Given this list of marker genes TPSAB1 (NCBI Gene Id 82314), ADAMTS18, FN1, JAM2, MMP17, CEACAM6, CTSG, KLK7, CD44, CRTAP, LAMA1, CAPN14, FGB, TLL1, FGG, COL20A1, VCAN, ADAMTS4, ACTA1, ACTB, LAMA3, COL4A1, ITGAX, BCAN, JAM3, COL11A2, VCAM1, HTRA1, MMP25, COMP, COL7A1, COL25A1, COL6A1, ADAMTS16, TIMP1, COL8A1, MMP11, PTPRS, PLOD2, CAPN8, COL22A1, SCUBE1, ASPN, KLK2, PLEC, DCN, FBN3, CD151, APP, SGCZ, SNTG2, ICAM2, PSEN1, FGF2, CAST, TGFB1, P3H2, LTBP4 (latent transforming growth factor beta binding protein 4), FURIN, ADAM15, CAPN15, NID2, MFAP2, SERPINH1, COL6A5, COL28A1, P3H1, EMILIN1, SPARC, COL12A1, FBLN1, ACTG1 (actin gamma 1), MATN3, DAG1, COLGALT2, SGCB, ADAM9, OPTC, ICAM5, ITGAV, COL3A1, COL21A1, NCSTN, MMP24, COL4A2, TNR, EFEMP1, CD47, SPOCK3, COL5A1, COL14A1, ADAM8, ITGA8, CTSL, SH3PXD2A, P3H3, CAPN7, ADAMTS14 (ADAM metallopeptidase with thrombospondin type 1 motif 14), CAPN11, SDC2, ELANE, FMOD (NCBI Gene Id 2331), PLG, MATN4, CAPN10, NRXN1, ITGB1, ITGB2, COL10A1, BMP2, CAPN2, DMP1, LTBP3, P4HB, EMILIN3, ADAM12, DRP2, TTR, SNTB1, COL27A1, LOXL1, COL13A1, FBN2, COL9A2, KDR, CAPN3, EFEMP2, ITGAM, CTSB, LAMA5, TNC, COL18A1, DTNA, COL1A1, ITGB5, CAPN13, PRKCA, ADAMTS2, LAMC3, TRAPPC4, COL4A5, MFAP3, SDC1, ACTN1, SCUBE3, TGFB2, GDF5, CAPN9, ADAM19, LOXL4, BMP10 (NCBI Gene Id 27302), LOXL2 (lysyl oxidase like 2), MMP16, PXDN, CTSD, MADCAM1, COL11A1, ICAM3, ITGA2B, SERPINE1, MMP15, KLKB1, MMP7, LAMC1, ADAMTS8, MMP12, FBN1, SPP1, CTSV, CTRB2, PECAM1, ITGB8, ITGB6, MMP3, COL5A3 (NCBI Gene Id 50509), MMP9 (matrix metallopeptidase 9), SNTB2, SGCA, A2M, DSPP (dentin sialophosphoprotein), ADAMTS9, COL8A2, ITGAD, MATN1, CAPNS2 (calpain small subunit 2), COL1A2, LAMC2, SGCG, COL2A1, CAPN12, LUM, PRSS1, ITGB3, COL17A1, LAMA4, HSPG2, FGA, NCAN, DMD, DDR2 (NCBI Gene Id 4921), ELN, ADAM17, MMP2, ITGA6, PLOD3, BSG, COL4A4, ITGA11, AGRN, MUSK, ADAM10, FBLN5, ITGA4, CTSS, CASP3, ITGA3, ADAMTS1, HAPLN1, COL24A1, ADAMTS3, EMILIN2, ACAN, PPIB, PDGFA, F11R, ACTA2 (NCBI Gene Id 59), MMP13, COL6A2, LAMB3, PCOLCE, ITGA2, MFAP5, SSPN, TIMP2, ITGAL, DST, COL19A1, NTN4, COL6A3, LAMB1, DTNB, NCAM1 (neural cell adhesion molecule 1), CEACAM8, LTBP1, LOXL3, P4HA1, LOX, TLL2, CAPN6, LRP4, PCOLCE2, CAPNS1, PLOD1, ACTG2, BMP4, MFAP4, CAPN5 (calpain 5), COL26A1, ITGB4, CMA1, LAMA2, BMP7, ICAM4, MMP14, P4HA2, SNTA1, COL16A1, BGN, ITGAE, SGCD, SDC3, COL4A3, CEACAM1, TNXB, UTRN, COL6A6, PRSS2, CDH1, COLGALT1, ITGA7 (integrin subunit alpha 7), PHYKPL, CAPN1, CASK, MMP20, MMP19, COL15A1, TGFB3, NID1, COL4A6 (collagen type IV alpha 6 chain), MMP10, MMP1, CTSK (NCBI Gene Id 1513), COL5A2, P4HA3, ICAM1, ADAMTS5, VTN, COL23A1, ITGA9, TNN, TMPRSS6, ITGB7, LTBP2, MMP8, VWF, PDGFB, FBLN2, THBS1, COL9A1, IBSP, ITGA10, ACTC1, CTRB1, SGCE, DDR1, COL9A3, SDC4, ITGA5, ITGA1, LAMB2, BMP1, here is a description of the gene set: species: Homo sapiens The extracellular matrix is a component of all mammalian tissues, a network consisting largely of the fibrous proteins collagen, elastin and associated-microfibrils, fibronectin and laminins embedded in a viscoelastic gel of anionic proteoglycan polymers. It performs many functions in addition to its structural role; as a major component of the cellular microenvironment it influences cell behaviours such as proliferation, adhesion and migration, and regulates cell differentiation and death. <br><br>ECM composition is highly heterogeneous and dynamic, being constantly remodeled and modulated, largely by matrix metalloproteinases (MMPs) and growth factors that bind to the ECM influencing the synthesis, crosslinking and degradation of ECM components. ECM remodeling is involved in the regulation of cell differentiation processes such as the establishment and maintenance of stem cell niches, branching morphogenesis, angiogenesis, bone remodeling, and wound repair. Redundant mechanisms modulate the expression and function of ECM modifying enzymes. Abnormal ECM dynamics can lead to deregulated cell proliferation and invasion, failure of cell death, and loss of cell differentiation, resulting in congenital defects and pathological processes including tissue fibrosis and cancer.<br><br>Collagen is the most abundant fibrous protein within the ECM constituting up to 30% of total protein in multicellular animals. Collagen provides tensile strength. It associates with elastic fibres, composed of elastin and fibrillin microfibrils, which give tissues the ability to recover after stretching. Other ECM proteins such as fibronectin, laminins, and matricellular proteins participate as connectors or linking proteins.<br><br>Chondroitin sulfate, dermatan sulfate and keratan sulfate proteoglycans are structural components associated with collagen fibrils (Scott & Haigh 1985; Scott & Orford 1981), serving to tether the fibril to the surrounding matrix. Decorin belongs to the small leucine-rich repeat proteoglycan family (SLRPs) which also includes biglycan, fibromodulin, lumican and asporin. All appear to be involved in collagen fibril formation and matrix assembly (Ameye & Young 2002). <br><br>ECM proteins such as osteonectin (SPARC), osteopontin and thrombospondins -1 and -2, collectively referred to as matricellular proteins appear to modulate cell-matrix interactions. In general they induce de-adhesion, characterized by disruption of focal adhesions and a reorganization of actin stress fibers. Thrombospondin (TS)-1 and -2 bind MMP2. The resulting complex is endocytosed by the low-density lipoprotein receptor-related protein (LRP), clearing MMP2 from the ECM.<br><br>Osteopontin (SPP1, bone sialoprotein-1) interacts with collagen and fibronectin. It also contains several cell adhesive domains that interact with integrins and CD44.<br><br>Aggrecan is the predominant ECM proteoglycan in cartilage (Hardingham & Fosang 1992). Its relatives include versican, neurocan and brevican. In articular cartilage the major non-fibrous macromolecules are aggrecan, hyaluronan and hyaluronan and proteoglycan link protein 1 (HAPLN1). The high negative charge density of these molecules leads to the binding of large amounts of water. Hyaluronan is bound by several large proteoglycans proteoglycans belonging to the hyalectan family that form high-molecular weight aggregates, accounting for the turgid nature of cartilage. <br><br>The most significant enzymes in ECM remodeling are the Matrix Metalloproteinase (MMP) and A disintegrin and metalloproteinase with thrombospondin motifs (ADAMTS) families (Cawston & Young 2010). Other notable ECM degrading enzymes include plasmin and cathepsin G. Many ECM proteinases are initially present as precursors, activated by proteolytic processing. MMP precursors include an amino prodomain which masks the catalytic Zn-binding motif (Page-McCawet al. 2007). This can be removed by other proteinases, often other MMPs. ECM proteinases can be inactivated by degradation, or blocked by inhibitors. Some of these inhibitors, including alpha2-macroglobulin, alpha1-proteinase inhibitor, and alpha1-chymotrypsin can inhibit a large variety of proteinases (Woessner & Nagase 2000). The tissue inhibitors of metalloproteinases (TIMPs) are potent MMP inhibitors (Brew & Nagase 2010). Reactome Pathway: Extracellular matrix organization